The following is a description of a gene set: Any process that activates or increases the frequency, rate or extent of calcineurin-mediated signaling. studied in species Mus musculus Mouse Gene Set: GOBP_POSITIVE_REGULATION_OF_CALCINEURIN_MEDIATED_SIGNALING, and this is the list of marker genes: Akap6, Tnf, Igf1, Akap5, Ppp3r1, Ptbp1, 3425401B19Rik, Cherp, Nrg1 (neuregulin 1), Sppl3, Lmcd1, Ppp3r2, Slc9a1, Camta1, Erbb3, Ppp3cc, Clec7a, Ppp3ca, Cib1 (NCBI Gene Id 23991), Chp2, Ppp3cb